Given this list of marker genes TNFAIP3, UBA52, RBCK1, BIRC3, XIAP, RNF31, BIRC2, TRADD, TAB2, OTUD7B, RIPK1, IKBKB, RACK1 (NCBI Gene Id 90938), OTUD1 (NCBI Gene Id 220213), UBB, RPS27A, TRAF2, UBC, TAB1, SHARPIN, OPTN, IKBKG, TNF, CHUK, TRAF1, SPATA2, TAB3, USP2, CYLD, USP4, USP21, TNFRSF1A, MAP3K7 (NCBI Gene Id 6885), here is a description of the gene set: TNFR1-induced NF-kappa-B signaling pathway species: Homo sapiens Human Gene Set: REACTOME_TNFR1_INDUCED_NF_KAPPA_B_SIGNALING_PATHWAY